Given this list of marker genes TAF10, FNTA, CRAT, HAT1, SMARCE1, KAT2B, NAA60, ATF2 (activating transcription factor 2), KAT2A, HGSNAT, USP22, ING3, NAT2, GNPAT, NCOA1, SERINC1, FNTB, NUPR1, IFNB1, CREBBP, NAT1, NAA16, NAA11, KAT7, CHAT, HADHA, ESCO1, SAT2, ELP3, SATL1, GCAT, DBT, BCAS3, SAT1, ING4, KAT6B, LPCAT1, TAF1L, CDY2B, PHF10, LCAT, NAA15, CDY1B, SRCAP, CDY1, BLOC1S1, MEAF6, BRPF3, NCOA3, NAA25, NAA80, BAZ1A, AANAT, KAT14, TADA2A, NAA40, PYGO2, NAT8, ACAT1, NAA30, EP300 (E1A binding protein p300), NAT8B, CLOCK, LPCAT2, ABHD14B, DLAT, CDY2A, GTF3C4, NAT14, SPHK1, HADHB, NAGS, BRD1, BRPF1, GNPNAT1, TAF1, NAT9, NAA10, CASD1, BRCA2, PAFAH2, ACAA1, MCM3AP, ESCO2, FASN, KAT5, JADE1, KAT6A, NAT10, NAP1L2, MOGAT2, ATAT1, GTF2B, NAA20, PAFAH1B2, JADE2, KAT8, LPCAT4, PAFAH1B3 (NCBI Gene Id 5050), NAT8L, TAF9, PDCD5, NAA50, ACAT2, TMEM68, SERINC2 (serine incorporator 2), ACAA2, ARRB1, here is a description of the gene set: studied in species Homo sapiens Catalysis of the transfer of an acetyl group to an acceptor molecule. Human Gene Set: GOMF_ACETYLTRANSFERASE_ACTIVITY